Given this list of marker genes 7a, M, SARS coronavirus, complete genome, S, E, 3a, N, here is a description of the gene set: species: Homo sapiens Reactome Pathway: Virion Assembly and Release_9679509 SARS viral assembly occurs at the ERGIC membrane. Membrane protein components of the virus concentrate at the ERGIC membrane but are also found throughout the secretory system including at the plasma membrane. Accumulation at the site of viral assembly has been shown to depend on interaction between retrieval signals in the cytoplasmic tails of viral proteins and host factors such as the COPI coat, and likely involves repeated rounds of anterograde and retrograde traffic.<br>Viral assembly is intitiated by homotypic interactions of M protein. This forms an M-lattice that contributes to the induction of membrane curvature and additionally acts as a scaffold for the recruitment of the other structural components of the virus. M protein makes interactions with each of the main components of the mature virus, including E, S and N. Electron micrographic studies suggest the final size of the mature virus is ~100 nm. The ribonuclear particle is predominantly helical and is packaged with an outer diamter of ~ 16 nm. These physical constraints suggest a final stoichiometry in the mature virion of 75 S trimers:1200 M proteins:300 N:1 RNA genome. Minor amounts of other viral proteins, including proteins E, 3a and 7a may also be components of the mature virus, although their functions are not well established. part of: SARS-CoV-1 Infection